Given this list of marker genes BHMT, IDO1, AGXT2, GAD2, AZIN2, AADAT, ATP2B4, ICMT, ALDH18A1, MTRR, AASDH, IDO2, EGLN2, P4HB, SLC25A2, ASS1, OTC, ARG2, GOT2, PARK7 (NCBI Gene Id 113880), CAD, NOX4 (NADPH oxidase 4), ALDH1A1, MMUT, DDO, GNMT, KYAT3, DDAH1, DAOA, MPST, PLOD2, SLC1A3, ENSG00000274276, MTHFD1, SARDH (sarcosine dehydrogenase), ABAT, ALDH8A1, BLMH, TDO2 (tryptophan 2,3-dioxygenase), BPHL, DPYD, GAD1, UPB1, KYNU, HNF4A, MTHFR, MTR, DAO, KMO, KYAT1, ASL, PHGDH, CTH, ALDH4A1, CBS, AFMID, SLC38A1, ALDH5A1, DDAH2, PLOD3, DPEP1, PRODH, SRR, HOGA1, ARG1, CPS1, here is a description of the gene set: Human Gene Set: GOBP_NON_PROTEINOGENIC_AMINO_ACID_METABOLIC_PROCESS studied in species Homo sapiens The chemical reactions and pathways involving non-proteingenic amino acids.